The following is a description of a gene set: Mouse Gene Set: GOBP_SECRETORY_GRANULE_LOCALIZATION species: Mus musculus Any process in which a secretory granule is transported to, and/or maintained in, a specific location within the cell., and this is the list of marker genes: Pik3cg, Sybu, Myo5a, P2rx7, Unc13d, Tanc2, Kif1a, Myo5c, Rab3a, Cadps, Uso1, Unc13b, Ppfia2, Kif1b, Kif5b, Syt4, Mapk8, Mecp2, Rasgrp1, Unc13c, Tcf7l2, Syt10, Trim46, Map2, Stxbp1, Kif1c, Eipr1, Cadps2, Baiap3, Snap25, Kif5a, Stxbp3, Unc13a, Rims1, Stxbp2, Syt6